The following is a description of a gene set: Human Gene Set: LEE_BMP2_TARGETS_DN Genes down-regulated in uterus upon knockout of BMP2. from publication Lee KY, Jeong JW, Wang J, Ma L, Martin JF, Tsai SY, Lydon JP, DeMayo FJ (PMID 17515606) The process of implantation, necessary for all viviparous birth, consists of tightly regulated events, including apposition of the blastocyst, attachment to the uterine lumen, and differentiation of the uterine stroma. In rodents and primates the uterine stroma undergoes a process called decidualization. Decidualization, the process by which the uterine endometrial stroma proliferates and differentiates into large epithelioid decidual cells, is critical to the establishment of fetal-maternal communication and the progression of implantation. The role of bone morphogenetic protein 2 (Bmp2) in regulating the transformation of the uterine stroma during embryo implantation in the mouse was investigated by the conditional ablation of Bmp2 in the uterus using the (PR-cre) mouse. Bmp2 gene ablation was confirmed by real-time PCR analysis in the PR-cre; Bmp2fl/fl (termed Bmp2d/d) uterus. While littermate controls average 0.9 litter of 6.2+/-0.7 pups per month, Bmp2d/d females are completely infertile. Analysis of the infertility indicates that whereas embryo attachment is normal in the Bmp2d/d as in control mice, the uterine stroma is incapable of undergoing the decidual reaction to support further embryonic development. Recombinant human BMP2 can partially rescue the decidual response, suggesting that the observed phenotypes are not due to a developmental consequence of Bmp2 ablation. Microarray analysis demonstrates that ablation of Bmp2 leads to specific gene changes, including disruption of the Wnt signaling pathway, Progesterone receptor (PR) signaling, and the induction of prostaglandin synthase 2 (Ptgs2). Taken together, these data demonstrate that Bmp2 is a critical regulator of gene expression and function in the murine uterus. studied in species Mus musculus, and this is the list of marker genes: WDR36, PRMT7, OBI1, HSP90AA1, QRSL1, MYBBP1A, DONSON, SNHG3, CCT6A, PPP1R8, ADAMTS9, GPS1, CHAF1B, DNAAF2, CDK7, SAV1, E2F3, RPL41, EIF2S1, GJA1, RPA2, PINX1, GAR1, DCTD, PFDN4, NUP155 (NCBI Gene Id 9631), CDYL, HBEGF, KCTD13, JARID2, AOC1, FOSL1, IFRD1, WDR75, TFRC, PPID, SLC16A3, AIFM1, SDAD1, RRP1B, RIF1 (NCBI Gene Id 55183), CCNE1, NKRF, EEF1E1, CSRNP2, CENPQ, SLC16A1, UCHL5, POF1B, CASP8AP2, RPS9 (NCBI Gene Id 6203), CDC45, EIF1AY, RRP15, PHF5A, EXOSC8 (exosome component 8), TCERG1, NABP1, NLN, PTCD3, COX18, BRIX1, GAS5, RRM1, RPS6KB1, NETO2, HMGN5, PPAT, TOMM20 (translocase of outer mitochondrial membrane 20), KPNA1, SLC7A6 (solute carrier family 7 member 6), UBA3, SACS, PPAN, PRMT6, PDXP, CIP2A, GEMIN4, SLC35D1, RRM2, WDR3, NUP43, TARS2, BTAF1, LUC7L, HEATR3, CISD1, ALG3, DDX27, GNPTAB, TIMM17A, FRA10AC1, JAK1, NUP160, C11orf24, ACP1, YARS2, HUS1, DNAJA4, TRIM59, NUDCD1, TIMM23, NOP16, RUVBL2, HAUS6, FAM149A, UNC5B, MIR17HG, LBHD1 (NCBI Gene Id 79081), TMEM30A, DIS3, PGK1, POP1, PURB, HDAC2, BEND3, MLLT11, HTRA2, LDLR, UBQLN1, PAFAH1B2, HDHD2, SLC19A1, AURKA, L2HGDH, DCTPP1, IER5, APLN, KCND3, RANBP1, POLRMT, CENPW, FPGS, VRK1, FOXN2, PPRC1, ZCCHC10, HOGA1, APPBP2, NOC4L, FOXRED1, BCCIP, FAM136A, RASGRP1, WDR74, ZNF131, NOL8, MFSD2A, ZC3H8, ECRG4 (NCBI Gene Id 84417), ISG20L2, MSH6, SPDL1, GEMIN5, PTX3, CINP, GMNN, CENPS, PSMC3IP, TMEM69, RCC1L, SCOC, CSTF3, FGF7, INTS2, HSPA8, DNAJB1, MTHFD1, FKBP3, SLC7A1, ARL6IP6, ERGIC2, LSM8 (LSM8 homolog, U6 small nuclear RNA associated), HAUS7, PCSK5, CDC6, SRSF1, ATIC, EVA1C, C18orf54, MIS18A, NIP7, UMPS, DNMT1, VEGFA, AGFG1, TIMMDC1, LNPK, MNS1, DHX29, PIGA, DKC1, DDX56, PPM1D, ACTL6A, POLE4, TAF4B, ZNF148, DNAJA2, ABCE1 (ATP binding cassette subfamily E member 1), WDR76, PGAP1, PDF, IL1R1, TBX3, HELLS, NAT10, PSAT1, GNL3, UTP15, NIFK, XPOT, ADORA2B, PBDC1, SFPQ, NQO2, DCBLD1, MCTP2, EMILIN2, PSMD6, HAT1, RBM19, CLSPN, S100A8, TMEM199, MAK16, DCK, SLC2A3, KRTDAP, KPNA4, EPB41L1, SIMC1, CDR2, MRPS2, PA2G4, SLC30A2, ZMYND19, NUP205, OXNAD1, RBM12, PRRX2, NDC1, DDX39A, UBA2, DBF4, AFG2A, UCHL3, RGCC, SMCHD1, MEDAG, RUNX1, JPH1, MARS1, ANGPT1, HSPA14, UTP18, HSPH1, HDAC4, PARM1, SUPV3L1, NOP58, HSPA5, PWP2, GRWD1, BHMT, FAM111A, ID1 (inhibitor of DNA binding 1), EXO1, RAD23B, B4GALT5, MTHFD2, SMARCA5, RPL12, WDR46, MRPS18B, CLUH, COX10 (cytochrome c oxidase assembly factor heme A:farnesyltransferase COX10), DNPH1, VKORC1L1, PMPCA, ZNRD2, HAUS5, POLR1A, PFN2, TRMT6, CTNNBL1 (catenin beta like 1), RBP7, SRPK1, PKDCC, NGEF, EZH2, ELOVL2, LRRC59, PNN, FIRRM, MTRR, NOA1, ST8SIA2, UBE2F, SH3PXD2A, BORA, MLEC, PSMD12, RANGRF, SLC20A1, AMD1, CSRNP1, DUT, NAV3, SF3B3, TRUB1, PANK3, RRAS2, NT5C3A, NME1, SEH1L, CBX2, WT1, NMD3, GTF2E1, MCM4, PNO1, RAB32, TGOLN2, NUP85 (NCBI Gene Id 83705), EPHA4, DUS4L, NUDT5, GINS1, FIGNL1, NUS1, LRPPRC, PRSS35, STIP1, SAMD4A, NLE1, ALDH5A1, ZMYM1, DRD4, RPS24 (NCBI Gene Id 6229), FASTKD2, TLR3, CKS1B, MMGT1, CCNE2, NOL10 (NCBI Gene Id 80085), KLHL29, YAF2, AGPAT5, OTUD6B, BAMBI, MRPL50, UTP4, ST6GALNAC4, NUP107, STEAP1, CDT1, SYNPO2, GTF2E2, DLAT, SDF2L1, NUP93, HEATR1, RPP40, ACKR3, AHSA1, PUM3, NOC2L, ATAD5, SNRNP40, FASTKD1, TOMM5, SERPINB9, PDCD11, MTHFD1L, GCH1, AMOTL2, CYC1, SEC23IP, WDHD1, GSTCD (NCBI Gene Id 79807), TIMM10, ATAD3A, FANCA, DNAJB11, SINHCAF, SMAD7, AK4, UTP20, SNU13, STRAP, CCDC86, PRP4K, ME1, ADI1, NIN, LYAR, HSPD1, PDS5A, GART, P4HA2, HSD17B7, MRTO4, MPHOSPH10, NDP, CD38, NOCT, FLVCR1, KPNB1, TEDC2, PSMD5, USP10, CXCL14, LRP12, RRN3, COQ10B, COL14A1 (NCBI Gene Id 7373), DHFR, MB21D2, DDX51, TRIP13, MRE11, TIMM8A, NUP153, RECQL (RecQ like helicase), ANP32E (NCBI Gene Id 81611), WDR77, KLF5, BZW1, PXDC1, KRR1, TTK, CEP192, FAM227B, DPH2, PLAA, PIM3, USP46, DDX21, NVL, SECISBP2, PDSS1, DOT1L, EXOSC1, SLC41A2, EHD1, ACOD1, CCT3, NSUN2, TXNRD1, MED8, RRS1, AHSA2P, NAA15, PTPRG, HDAC1, MOGS, CYP3A5, NUP54, MCM6, TIAM1, YWHAG, FGA, WNT6, EIF4E, TARDBP, ELOC, SERPINB6, HK2, CAD, RBMX, CCT7, EAF1, SHMT1, RTEL1, MTF1, YDJC, URB1, LMAN1, ATAD2, TSR2, TRAIP, IHH, TAF2, RIOK3, ESF1, ZWINT, GTPBP4, NAB2, SRSF3, PTGS2, TTF2, EPHB2, POLR1F, YAE1, CACTIN, CYP51A1, WDR43, EXOC3L2 (exocyst complex component 3 like 2), RBMX2, GTPBP10, RNF138 (NCBI Gene Id 51444), WDR55, COPS8, MMACHC, RAD51, NUP50, NRN1, RNF4, FSCN1, NUP37, NARS1, FANCB, TNFAIP2, HSPA9, LMNB2, SGO1, MCM7, ENAH, AASS, KTI12, PUS7L, CLNS1A, MANF, PCMT1, THEM5, CIAPIN1, POLR3K, PHF20L1, LIMK1, TMX1, GMPS, SRSF10, TRMT10C, DDX18, C10orf88, FAM210B, MAP3K7, DDX20, ORC2, FOXK2, RWDD4, ETNK1, G3BP1, FSTL3, CARNMT1, CYP11A1, PRMT3, TIMM9, FST, NECTIN3, CDC73, BAZ1A, BYSL, TRA2A, FKBP4, BASP1, TAF5, BRCA1, ASNS, PAXIP1, CACYBP, PARP1, CTPS1, HSPA4, TMOD2, SSB, URB2, PHGDH, FKBP5, DIMT1, MEX3A, ZNF484, CDC25A, MCM2, FAM98A, TOPBP1, FRAT1, CLIC6, NUCKS1, PGD (NCBI Gene Id 5226), PRELID3B (NCBI Gene Id 51012), UCK2, NDUFAF4, KMT5A, PGAM1, USP24, E2F7, DACT1, NOTUM, PNPT1, LY75, SNORD30, NOL9 (NCBI Gene Id 79707), TSR1, RRP12 (ribosomal RNA processing 12 homolog), RAPH1, MLLT3, PRPF40A, RPF2, GMFB, LSM3, FADS3, HAND2, DBR1, SSR1, NAA50, PUS3, HMGCR, NOL11, SNRPA1, TCOF1, RXRA, NEMP1, ID3, PSPH, ASF1B, JMJD6, CHORDC1, NOL4L, MGAT2, ZWILCH, RAD17, DTL, SLC11A2, E2F8, SKP2, PPP2R1B, BMPER, DCLRE1B, IRAK3, MRPL20, GSPT1, AKR1B1, CSE1L, COQ7, SPTLC2, RETSAT, DNAJC21, DNAAF10, LARP4, NOP56, ORC6, AEN, NOP2, NT5E, TRAPPC4, PCLAF, ROR1, LARP1, PTN, MTO1, NCAPD3, RCC2, TAF1D, NOLC1, NUDCD2, NECAP1, PRSS12, UAP1, AZIN1, MTAP, CUL3, PRMT1, CDK2AP1, XPO4, WDR5, XRCC6, SUV39H1, NAA20, CYCS, RPS6KA6, USP1, CNN3, DNA2, PRKCI, LRR1, IDI1, EDEM1, ZMIZ1, MAD2L1, SLC25A32, MOAP1, TXNL1 (NCBI Gene Id 9352), DHX33, AKIRIN1, IARS1, USP45, GPD1L, SCT, DNAJA3 (DnaJ heat shock protein family (Hsp40) member A3), CENPI, PFAS, OPA1, BOP1, CAND2, NASP, TBL3, SNAI1, WEE1, HSPE1, SLC25A13, MTREX, BLM, TAB3 (TGF-beta activated kinase 1 (MAP3K7) binding protein 3), NIPAL1, PDE3B (NCBI Gene Id 5140), PRKG2, CEP76, FUBP1, ANKRD26, ILF2, ASS1, TMEM167A, SMC3, WDR18, CSTF2, PDGFC, APEX1, KPNA2, MDN1, MCTS2, ENC1, LPGAT1, CHCHD4, SEMA6D, HNRNPAB, INTS11, POLR1E, ADAM12, PLK4, TAC3, METTL16, MAT2A, MRM3, GLA, DUSP9, GEMIN6, ORC4, SQLE, PSME3, PDE12, SNAPC3, SRM, CRY1, MCM5, SLF1, PCGF6, PSPC1, EBNA1BP2, ENOPH1 (enolase-phosphatase 1), IDH3A, TMTC1 (transmembrane O-mannosyltransferase targeting cadherins 1), DNAJC2, CCT8, RAD51AP1, KNOP1, CDCA7, KCMF1, TMED5, EXOC5, IGSF11, MELK, SYNCRIP, GJB2, XPO5, MCM3, CHEK1, MMS22L, SRSF7, TEX30, USP31, COL22A1, LEO1, THUMPD3, ARHGAP20, TBRG4, DDI2, ACOT11, SLC39A6, USP53, SHQ1, NAA25, LTV1, PWP1, TIPIN, BUB1, ZDHHC13, CRELD2, WNT4, HAUS3, PIN1, NAMPT, DLK2, DHODH, MRPL18 (NCBI Gene Id 96273), MRPS22, FASTKD5, FAIM, LDHA, SPRYD7, JCAD, VMA21, BMP2, FEN1, AARS1, C1QBP, UNG, PGAM5, KAZALD1, RND3, NUP58, NCBP1, XPO1, EIF2S2, NAF1, MPI, UTP6, ADAMTS2, PRKAB2, THOP1, TNFRSF12A, TOMM70, UTP25, LIN54, RNPS1, NARS2, RPL7L1, MAP7D2, TARBP1, YTHDC2, SMYD5, UHRF1, SRFBP1, ABHD10, RCC1, RAN, PPA1, PLEKHG4, SZRD1, CHN1, NUP35, MCM10, CPSF6, CCNYL1 (NCBI Gene Id 151195), TFDP1, PPIF, TTLL4, NOC3L, POLE2, AK2 (adenylate kinase 2, NCBI Gene Id 83165), LSM6, NFATC2IP, PRPS1, LSM12, RBM3, RPP30, SHMT2, TDG, RPA1, QSOX2 (NCBI Gene Id 169714), C9orf40, ODC1, MAPK6, POLR1B, RRP8, PHLDA2, GFM1, EIF3J, C1orf131, USP39, DNAJC3, EIF2B3, FARSB, MTFR1, SUV39H2, GOLT1B, QTRT2, WDR12, RUVBL1, FAM118B, PTRH2, DANCR, WDR4, ETF1, FUT8, DAAM2, NOMO1, CHD1, SKA3, SERPINE1, TMEM33, NUP88, NHP2, TANK, TNFAIP8, SHISA3, TMEM97, ELAC2, TDO2 (NCBI Gene Id 6999)